Given this list of marker genes KDM3B, SPEN, SDC3, RTL8A, SEMA4D, DCAF12, XKR3, ERC1, DNAJC15, SPC24 (NCBI Gene Id 147841), CCDC73, SEMA6D, MPV17L, MAN1A2, CEBPZOS, CPEB4, IDH1, MDM4, PTBP2, ZFAND3, FOSL1, PARD6B, EIF4B, CCSER2, MAF, CCAR2, HAUS4, ADCY7, ZNF528, LUZP1, PLAC8, ALDH6A1, MRPL32, CBL, ZNF490, NACA, KCNN3, GADL1, CNPY1, FERRY3, BTC, ANKDD1A (NCBI Gene Id 348094), TNFRSF11A, NAPB, SNX1, ZNF37A, ERI2 (ERI1 exoribonuclease family member 2), GNA11, PGA3, OCA2 (NCBI Gene Id 4948), FBXL16, CCBE1, UBE2L3, PGA5, TRAF3, MAEL, CNTNAP3, ANKRD1 (NCBI Gene Id 27063), RC3H1, MAP3K9, MOSMO, BMP3, CHRD, ASB15, STK38, FOXN2, TASOR, CNOT4, PODXL, GPI, SP140L, SMOC2, STAP1, LRFN5, RAB15, GEMIN8, POLR1G, PLXNA2, BACH1, PLP1, METAP2 (methionyl aminopeptidase 2), MTX3, ATP1B4, BDP1, CBX5, OGT, TFCP2L1, SCAI, LRAT, TMEM126B (transmembrane protein 126B), KMT2E, C4orf46, UBE2N, GSTM1, LRATD1, PGA4, TAF11, SLC24A4, ATXN7, FOXK1, ASB6, TRAF6, KIF24, MSL2, MTFMT, APOL6, EFCAB2 (NCBI Gene Id 84288), TFDP2, XPNPEP3, PIM2, SPACA9, AASDH, SP140, ASCC1, MAP7D3, BCL7A, TBCB, SUN2, UHMK1, CNTNAP3B, IL31RA, SF3B3, HGF, RECQL5, WIPF2, DCX, NF2, IRGQ (immunity related GTPase Q), BBS10, PDP2, RRM2, ZNF850, SPIRE1, ADAM12, TAT, CARHSP1, MID1, CBLN3, HOOK3, KRTAP5-5, PPP4R1, UBE2E3, EOLA1 (NCBI Gene Id 91966), POU2F1, PSMB11, SLC25A21, ZSCAN4, TRIM8 (tripartite motif containing 8), KIF18B, WDR89, FIGNL2, PIK3R1, HCN1, FAM114A1 (NCBI Gene Id 92689), SH3RF1, ARNT, LRRN2, FBXL18, CNBP, ATP8A2, LYN, SLC39A14, TTPAL, DNMT3A, KCNB1, KPNA6, DGKE, RALB, PAXBP1, DEPDC1B, INO80D, DAAM1, SARM1, RAB11A, AGER, SERP1, DNAJB4, CEACAM8 (NCBI Gene Id 1088), ZNF354C (NCBI Gene Id 30832), NAV1, PLPPR5, SLC35F1, DACH1, SHISA9, KRT10-AS1, FAM168A, ZKSCAN3, CAMTA1, BROX, SCRN2, FRS2, PANK2, TTC14, CGGBP1, TNFSF8, CCDC50, here is a description of the gene set: species: Homo sapiens Genes predicted to be targets of miRBase v22 microRNA hsa-miR-4768-3p in miRDB v6.0 with MirTarget v4 prediction scores > 80 (high confidence targets). from publication Chen Y, Wang X (PMID 31504780) Human Gene Set: MIR4768_3P